The following is a description of a gene set: studied in species Homo sapiens Visual phototransduction is the process by which photon absorption by visual pigment molecules in photoreceptor cells is converted to an electrical cellular response. The events in this process are photochemical, biochemical and electrophysiological and are highly conserved across many species. This process occurs in two types of photoreceptors in the retina, rods and cones. Each type consists of two parts, the outer segment which detects a photon signal and the inner segment which contains the necessary machinery for cell metabolism. Each type of cell functions differently. Rods are very light sensitive but their flash response is slow so they work best in twilight conditions but are not good at detecting objects moving quickly. Cones are less light-sensitive and have a fast flash response so they work best in daylight conditions and are better at detecting fast moving objects than rods.<br><br>The visual pigment consists of a chromophore (11-cis-retinal, 11cRAL, A1) covalently attached to a GPCR opsin family member. The linkage is via a Schiff base forming retinylidene protein. Upon photon absorption, 11cRAL isomerises to all-trans retinal (atRAL), changing the conformation of opsin to an activated form which can activate the regulatory G protein transducin (Gt). The alpha subunit of Gt activates phosphodiesterase which hydrolyses cGMP to 5'-GMP. As high level of cGMP keep cGMP-gated sodium channels open, the lowering of cGMP levels closes these channels which causes hyperpolarization of the cell and subsequently, closure of voltage-gated calcium channels. As calcium levels drop, the level of the neurotransmitter glutamate also drops causing depolarization of the cell. This effectively relays the light signal to postsynaptic neurons as electrical signal (Burns & Pugh 2010, Korenbrot 2012, Pugh & Lamb 1993).<br><br>11cRAL cannot be synthesised in vertebrates. Vitamin A from many dietary sources is the precursor for 11cRAL. It is taken from food in the form of esters such as retinyl acetate or palmitate or one of four caretenoids (alpha-carotene, beta-carotene, gamma-carotene and beta-cryptoxanthin). Retinoids are transported from the gut to be stored in liver, until required by target organs such as the eye (Harrison & Hussain 2001, Harrison 2005). In the eye, in the form 11cRAL, it is used in the retinoid (visual) cycle to initiate phototransduction and for visual pigment regeneration to ready the photoreceptor for the next phototransduction event (von Lintig 2012, Blomhoff & Blomhoff 2006, von Lintig et al. 2010, D'Ambrosio et al. 2011, Wang & Kefalov 2011, Kefalov 2012, Wolf 2004). Reactome Pathway: Visual phototransduction part of: Sensory Perception, and this is the list of marker genes: RLBP1, RDH10, DHRS9, CLPS, PRKCQ, RBP3, PPEF1 (NCBI Gene Id 5475), OPN1LW, OPN1MW (opsin 1, medium wave sensitive), GUCA1C, PDE6A, METAP2, GPC5, CYP4V2, METAP1, SAG, AKR1C4, LDLR, CNGB1, PLB1, LRP12, GUCA1A, RDH11, APOC3, RBP1, GPC6, AKR1C1, LRP8, GUCA1B, OPN1SW, BCO1, FNTB, AGRN, SDC4, APOA4, AWAT2, HSD17B1, SLC24A1, APOA1, LRP2, GRK7, PRKCA, HSD17B6, AKR1C3, GUCY2F, SDC2, BCO2, LRAT, LRP10, SDC1, CNGA1, RPE65, AKR1B10, GNGT1, GNB1, RBP2, GPC3, RETSAT, RCVRN, APOM, GNB5, APOA2, RGS9, SDC3, GPC4, GPC1, GPIHBP1, MYO7A, TTR, NMT1, ABCA4, PDE6B, PNLIP, DHRS3, APOB, PDE6G, RDH5, LRP1, APOC2, STRA6, GNAT1, NMT2, GRK4, GPC2, SDR9C7, CALM1, FNTA, GUCY2D, LPL, RDH8, RDH12, RBP4, CAMKMT, RGS9BP, RHO, APOE, RDH16, GRK1, HSPG2